Given this list of marker genes Gucy2c, Nppc, Gucy1a1, Gucy2f, Gucy1b1 (NCBI Gene Id 54195), Nppb, Gucy2d, Npr2, Gucy2g, Nppa, Npr1, Gucy2e, here is a description of the gene set: The chemical reactions and pathways resulting in the formation of cyclic GMP, guanosine 3',5'-phosphate. studied in species Mus musculus Mouse Gene Set: GOBP_CGMP_BIOSYNTHETIC_PROCESS